The following is a description of a gene set: Binding to an oligosaccharide, a molecule with between two and (about) 20 monosaccharide residues connected by glycosidic linkages. studied in species Mus musculus Mouse Gene Set: GOMF_OLIGOSACCHARIDE_BINDING, and this is the list of marker genes: Reg1, Sele, Reg3a, Lgals3, Mbl1, Reg2, Chid1, Lgals9, Loxl2, Itln1, Colec11, Lgals1, Reg3b, Lgals12, Selp, Reg3d, Reg3g, Sell